Given this list of marker genes KAT7, FBXO5, MCIDAS, INO80, E2F8, MCM2, SLFN11, DBF4B, MCM6, FGFR1, MCM3, LIG3, NBN, METTL4 (NCBI Gene Id 64863), CIZ1, DACH1, WIZ, MCM4, SSBP1, ATRX, DYNLL1, TIPIN, MCM7, CAMSAP3, MCM5, AICDA, GMNN, CDK2, TIMELESS, CDT1, AGER, GMNC, CDC7, ENDOG, SENP2, NUGGC, ZMPSTE24, E2F7, BCL6, TICRR, DBF4, WRNIP1 (NCBI Gene Id 56897), here is a description of the gene set: Human Gene Set: GOBP_REGULATION_OF_DNA_TEMPLATED_DNA_REPLICATION Any process that modulates the rate, frequency, or extent of DNA-templated DNA replication, the process in which new strands of DNA are synthesized. studied in species Homo sapiens